The following is a description of a gene set: Genes with promoters bound by PPARG at 36 h time point of adipocyte differentiation of 3T3-L1 cells (preadipocyte). from publication Wakabayashi K, Okamura M, Tsutsumi S, Nishikawa NS, Tanaka T, Sakakibara I, Kitakami J, Ihara S, Hashimoto Y, Hamakubo T, Kodama T, Aburatani H, Sakai J (PMID 19414603) species: Mus musculus Control of cell differentiation occurs through transcriptional mechanisms and through epigenetic modification. Using a chromatin immunoprecipitation-on-chip approach, we performed a genome-wide search for target genes of peroxisome proliferator-activated receptor gamma (PPAR gamma) and its partner protein retinoid X receptor alpha during adipogenesis. We show that these two receptors target several genes that encode histone lysine methyltransferase SET domain proteins. The histone H4 Lys 20 (H4K20) monomethyltransferase PR-Set7/Setd8 gene is upregulated by PPAR gamma during adipogenesis, and the knockdown of PR-Set7/Setd8 suppressed adipogenesis. Intriguingly, monomethylated H4K20 (H4K20me1) levels are robustly increased toward the end of differentiation. PR-Set7/Setd8 positively regulates the expression of PPAR gamma and its targets through H4K20 monomethylation. Furthermore, the activation of PPAR gamma transcriptional activity leads to the induction of H4K20me1 modification of PPAR gamma and its targets and thereby promotes adipogenesis. We also show that PPAR gamma targets PPAR gamma2 and promotes its gene expression through H4K20 monomethylation. Our results connect transcriptional regulation and epigenetic chromatin modulation through H4K20 monomethylation during adipogenesis through a feedback loop. Mouse Gene Set: WAKABAYASHI_ADIPOGENESIS_PPARG_BOUND_36HR, and this is the list of marker genes: Chuk, Tob1, Clint1, Sh3glb1, Plod3, Sap30l, Hic2, Kat14 (lysine acetyltransferase 14), Creb3l4, Ngly1, Oxsm, Aldh9a1, Lgals3bp, Cdc25a, Mdm2, Trit1, Disp2, Znhit1, Slc16a10, Dynlrb1, Zfp326, Adck2, Exoc6, Acyp2, Cuedc1, Mef2c, Pus10 (pseudouridylate synthase 10), Mtor, Calcoco1